Given this list of marker genes Galnt12 (NCBI Gene Id 230145), Muc15 (NCBI Gene Id 269328), Galnt16, Muc1, Galnt18, Muc5ac, B3gnt5, Muc4, Chst4, Muc19, A4gnt (NCBI Gene Id 333424), Galnt4, Galntl5, St3gal1, Gcnt4, B3gntl1, Muc13, Galnt17, Galnt5, Muc20, Gcnt7, B3gnt9, B3gnt6, St3gal4, C1galt1, B3gnt7, B3gnt2, St6galnac4, B3gnt3, B4galt5, Gcnt3, B3gnt8, Galnt1, St3gal3, Galnt7, Muc2, Muc16, Galnt6, Muc17, Galnt15, Galnt14, St3gal2, B4galt6, Galnt9, Galnt10, St6galnac2, B3gnt4, St6galnac3, Galnt2, Gcnt1, Galnt11, Muc6, Muc5b, C1galt1c1, St6gal1, Galnt3, Galntl6, Galnt13, Muc21, here is a description of the gene set: Mouse Gene Set: REACTOME_O_LINKED_GLYCOSYLATION_OF_MUCINS species: Mus musculus O-linked glycosylation of mucins